Given this list of marker genes Dnaaf6, Gmfb, Dnajc1, Mast4, Ints12, Sephs2, Rph3al, Fcgr2b, Plcxd3, Alg8, Fzd3, Bfar, Gm5878, Tph2, Ppa1 (NCBI Gene Id 67895), Ptprg (NCBI Gene Id 71324), Sp4 (NCBI Gene Id 70610), Nadk2, Irgq, Gata3, Fxn, Kirrel1, Satb2, Spats2l, Fam170b (NCBI Gene Id 105511), Ttpa, Ranbp9, Fgd6, Cdh8, Pars2, Dram2, Pin1, Map1b (NCBI Gene Id 268696), Ube2d3, Dnaaf9, Gpalpp1, Map2, Nbeal1, Osbpl9, Lrrc9, Slc6a20b, Nsg2 (neuron specific gene family member 2), H13, Ralgapa2, Ro60, Mblac1, Gpkow, Cdk6, Pcdh7, Ereg, Zfp385b, here is a description of the gene set: Mouse Gene Set: MIR_3098_5P studied in species Mus musculus Genes predicted to be targets of miRBase v22 microRNA mmu_miR_3098_5p in miRDB v6.0 with MirTarget v4 prediction scores > 80 (high confidence targets). from publication Chen Y, Wang X (PMID 31504780)